The following is a description of a gene set: Any process that activates or increases the frequency, rate or extent of macrophage migration. Human Gene Set: GOBP_POSITIVE_REGULATION_OF_MACROPHAGE_MIGRATION species: Homo sapiens, and this is the list of marker genes: TNFSF18, CSF1, TRPV4, MAPK3, RTN4, C5AR1, TREM2, IL34, CSF1R, MMP14, P2RY12, RARRES2, CXCL17, CCL2, P2RX4, CX3CL1, THBS1, CCL5, CCL3, CMKLR1, SLAMF1, C3AR1, MAPK1, PTK2, AKIRIN1, PTPRJ (protein tyrosine phosphatase receptor type J), MDK, MSTN